The following is a description of a gene set: Any process that stops, prevents or reduces the frequency, rate or extent of tight junction assembly. Human Gene Set: GOBP_NEGATIVE_REGULATION_OF_BICELLULAR_TIGHT_JUNCTION_ASSEMBLY studied in species Homo sapiens, and this is the list of marker genes: IKBKB, MIR105-1, TNF, MIR142, ROCK1 (Rho associated coiled-coil containing protein kinase 1), ROCK2, RPS6 (NCBI Gene Id 92956)